Given this list of marker genes Gm28471, Gm21803, Gm28220, Gm21409, Gm21879, Gm28440, Gm29115, Gm28106, Gm28301, Gm21720, Gm21095, Gm21088, Gm21785, Gm21287, Gm29338, Gm28219, Gm21782, Gm21734, Gm20862, Gm28365, Gm21838, Gm28658, Gm29393, Gm28671, Gm20854, Gm21477, Gm28978, Gm29390, Gm21777, Gm29504, Gm29503, Gm29299, Gm20860, Gm20819, Gm21394, Gm20820, Gm21813, Gm21462, Gm20856, Gm21435, Gm15247, Gm20879, Gm21380, Gm29476, Gm20863, Mid1-ps1, Gm20837, Gm20906, Gm21752, Gm21294, Gm29505, Gm28348, Gm21792, Gm21881, Gm21802, Gm28091, Gm21996, Gm29391, Erdr1, Gm28531, Gm21864, Gm28349, Gm21470, Gm28716, Gm28102, Gm21796 (predicted gene, 21796), Gm28368, Gm28107, Gm20861, here is a description of the gene set: Mouse Gene Set: chrYE species: Mus musculus